The following is a description of a gene set: Human Gene Set: GOBP_POLYAMINE_TRANSPORT studied in species Homo sapiens The directed movement of polyamines, organic compounds containing two or more amino groups, into, out of or within a cell, or between cells, by means of some agent such as a transporter or pore., and this is the list of marker genes: TAF7, ATP13A2, SLC22A3, SLC47A1, OAZ1, SLC22A16, SLC18B1, ATP13A5, OAZ3, SLC22A1, OAZ2, ATP13A4, SLC22A2, AZIN1, AZIN2, ATP13A3